Given this list of marker genes BDNF, SIM1, MC4R, NTRK2, GHRL, AGRP, LEP, POMC, GHSR (NCBI Gene Id 92434), NPY, ARNT, INS, INSR, LEPR, here is a description of the gene set: species: Homo sapiens Human Gene Set: WP_6Q16_COPY_NUMBER_VARIATION 6q16 copy number variation